Given this list of marker genes Ren1, Rhoa, Agtr1b, Npff (neuropeptide FF-amide peptide precursor), Agtr1a, Id2, Adra1b, Rarres2, Ephx2, F11r, Uts2, Wnk1, Tacr3, Camk2n1, Qrfp, Manf, Avpr2, Avp, Grip2, Cyp11b2, Oxtr, Tacr1, Ncf2, Adra2b, Adh5, Ptpn1, Crhr2, Agt, Hsd11b2, Ace3, Eng, Drd5, Tpm1, Avpr1a, Spx, Tac2, Adrb2, Nr2f2 (NCBI Gene Id 67192), Adrb1, Adra1d, Adra1a, Cnr1, Glp1r, Oxt, Lnpep, Tbxa2r, Or51e2, Cyba, G6pdx, Uts2r, Ace, Cyp2j5, Nr3c2, Cartpt, Atp5pf, Chrna7, Nmu, Adora1, here is a description of the gene set: Any process in which the force of blood traveling through the circulatory system is increased. Mouse Gene Set: GOBP_POSITIVE_REGULATION_OF_BLOOD_PRESSURE studied in species Mus musculus